Given this list of marker genes Sin3a, Gsk3b, Eprs1, Lef1, Mark3, Aimp1, Sumo1, Tbx3, Mlph (NCBI Gene Id 98687), Sox10, Kit, Iars1, Tcf7l2, Sirt1, Wnt3a, Kitl, Rars1, Csf1, Myrip (myosin VIIA and Rab interacting protein), Myo5a, Rab27a, Hint1, Aimp2, Tcf7l1, Usf1, Mapk3, Rps6ka1, Xpo1, Ube2i, Akt3, Mapk1, Mars1 (NCBI Gene Id 23941), Dars1, Eef1e1 (NCBI Gene Id 66143), Hdac1, Lars1, Tnfsf11, Ctnnb1, Mitf, Qars1, Mapk14 (NCBI Gene Id 26416), Ep300, Sytl2, Tcf7, Kars1, here is a description of the gene set: species: Mus musculus Mouse Gene Set: REACTOME_MITF_M_REGULATED_MELANOCYTE_DEVELOPMENT MITF-M-regulated melanocyte development